Given this list of marker genes LDLRAP1, NF1, GNA11, ADA2, JAK2, MEF2A, ZNF687, COL3A1, BUD23, EIF4H, NCF1, MLX, RFC2, PPARG, HTRA1, ELN, METTL27, GTF2IRD1, HEY2, FOXE3, CYP27A1, VAC14, MAT2A, THSD4, ANO1, TGFBR2 (transforming growth factor beta receptor 2), PCNT, ESR1, BAZ1B, ATP7A, SMAD4, PPP1R17, YY1AP1, DNAJC30, XYLT2, IDS, SLC2A10, SERPIND1, NOTCH3, CEP19, ABCC6, FIG4, LDLR, APOE, ENPP1, LIPC, VPS37D, GEMIN4, TGFBR1, MLXIPL, ABCA1, TMEM127, RET, IL12B, VHL, STAT1, PNPLA2, CLIP2, LIMK1, GTF2I, LOX, GPIHBP1, CYP7A1 (NCBI Gene Id 1581), MYLK, ARL6IP6, MFAP5, SMAD3, SMAD2, ABCG8, MYH11, TBL2, HLA-B, APOA1, TGFB3, APOB, ERCC8, GTF2IRD2, TMEM270, LMNA, SMPD1, AGXT, PRKG1, PCSK9, TGFB2, ACTA2, LRP6, ABCG5, STX1A, MAX, AEBP1, APOA2 (NCBI Gene Id 336), CELA2A, FKBP6, POU3F4, JAG1, GHR, MPL, BRCC3, F12, EPHX2, ERCC6, FBN1, THPO, BEST1, XYLT1, here is a description of the gene set: studied in species Homo sapiens Narrowing or constriction of the inner surface (lumen) of an artery. Human Gene Set: HP_ARTERIAL_STENOSIS Arterial stenosis